Given this list of marker genes Fbxo5, Rps6ka2, Zwint, Hormad1, Rad1, Zfy2, Trip13, Lif, Fbxo43, Dmrt1, Osm, Knl1, Nanos2, here is a description of the gene set: Mouse Gene Set: GOBP_NEGATIVE_REGULATION_OF_MEIOTIC_NUCLEAR_DIVISION species: Mus musculus Any process that stops, prevents, or reduces the frequency, rate or extent of meiosis.